The following is a description of a gene set: Pathway Definition from KEGG: UBQLN2* -| (Protein+UB) -- 26S -> Peptide Human Gene Set: KEGG_MEDICUS_VARIANT_MUTATION_INACTIVATED_UBQLN2_TO_26S_PROTEASOME_MEDIATED_PROTEIN_DEGRADATION Mutation-inactivated UBQLN2 to 26S proteasome-mediated protein degradation. Pathway ID: N01146. Pathway type: Variant. Pathway class: nt06464 Amyotrophic lateral sclerosis. studied in species Homo sapiens, and this is the list of marker genes: PSMA1, PSMD7, PSMD14, PSMD12, PSMD2, PSMB3, PSMC2, UBB, PSMA5, PSMD9, PSMD11, PSMD4, PSMA3, SEM1, PSMC3, PSMC5, PSMB2, PSMB1, PSMC4, PSMB6, UBA52, UBQLN2, PSMD3, PSMC6, ADRM1 (NCBI Gene Id 11047), PSMD13, PSMA4, UBC, PSMC1 (proteasome 26S subunit, ATPase 1), RPS27A, PSMD1, PSMA2, PSMD6, PSMB7, PSMA6, PSMB4, PSMA7, PSMD8, PSMB5, PSMA8